Given this list of marker genes Arid1a, Stil, Tfdp1, Ddx3x, Plrg1, Prkdc, Cyp1a1, Sass6, Gpnmb, Actb, Rpa2, Cenpj, Phb2, Ecd, Rrm1, Cul4b, Pbrm1 (polybromo 1), Bcl2, Cdc73, Tjp3, Susd2, Hyal1, Arid2, Rbl2, Eif4g1, Fbxo7, Smarcd2, Cdk7, Rb1, Cdk2ap2, Gpr15lg, Slfn1, Brd7, Cpsf3, Gli1, Csf1r, Ccnd3, Kank2, Cdkn2c, Cdkn2d, Id2 (inhibitor of DNA binding 2), Zc3h12d, Mn1, Fam83d, Dpf1, Lsm11, Crebbp, Mettl13, Akt1, Bcl7b, Dcun1d3, Plcb1, Rptor, Rdx (NCBI Gene Id 19684), AY074887, Ptpn6, Ankrd17, Ppp2r3d, Tbx2, E2f7, Ccnd1, Gjc2, Smarca4 (SWI/SNF related, matrix associated, actin dependent regulator of chromatin, subfamily a, member 4), Apc, Plcg2, Ccne1, Larp7 (NCBI Gene Id 652994), Plk3 (polo like kinase 3), Ctdsp2, Tcf3, Gas1, Pkd2, Bcl7a, Anp32b, Pdpn, Sox2, Trim39, Fam107a, Dpf3, Ambra1, Apex1, Cdkn1b, Acvr1, Cacnb4, Actl6b, Rpl17, Ube2e2, Stxbp4 (NCBI Gene Id 320264), Kcna5, Ccne2, Mlf1, Fhl1, Adamts1, Anxa1, Ccnh, Dact1, Egfr, Tmsb4x, Mepce, Cdkn2b, D1Pas1, Cirbp, Stox1, Pten, Plpp2, E2f1, Zfp655, Appl1, Ino80, Apbb1 (NCBI Gene Id 11785), Ddr2, Rps27l, Trp63 (transformation related protein 63), Crnn, Ccnd2, Fbxo31, Actl6a, Ctdsp1, Myo16, Cdkn1a, Ptprv, Wac, Psme2, Men1, Smarcc1, Rassf1, Rfwd3, Rrm2, Smarcd3, Mdm2, Haspin (NCBI Gene Id 14841), Tcim, Mir26a-2 (microRNA 26a-2), Mnat1, Psme3, Pkp3, Trp53, Btn2a2 (NCBI Gene Id 238555), Phf10, Gigyf2, Mtbp, Mir26a-1, Lsm10, Sde2, Smarcc2, Rbl1, Dgkz, Bcl7c, Paf1, Cul4a, Plk5, Fgf10, Dpf2, Mir26b, Rgcc (NCBI Gene Id 66214), Ctdspl, Dlg1, Adam17, Appl2, Ccl12, Jade1, Mblac1, Ppp2ca, Senp2, Cdkn2a, Pkd1, Bid, Klf11, Kif14, Inhba, Atp2b4, Tbx1, Dbf4, Psme1, Smarcd1, Smarce1, Tert, Smarcb1, Hacd1, Aif1, Tm4sf5, Kmt2e, Crlf3, Pagr1a, Ezh2, Smarca2, Trex1, Klf4, Prmt2, here is a description of the gene set: Any signaling pathway that modulates the activity of a cell cycle cyclin-dependent protein kinase to modulate the switch from G1 phase to S phase of the cell cycle. Mouse Gene Set: GOBP_REGULATION_OF_CELL_CYCLE_G1_S_PHASE_TRANSITION studied in species Mus musculus